Given this list of marker genes TSHZ3, IKZF3, SLC36A2, ORAI2, CTNND1, SEMA4G, IFT140, ABCC4, SLC16A1, SDC3, HYCC1, SKIL, CCT4, GAGE12D, VGLL3, MAP4K1, CDK8, FAM117A (NCBI Gene Id 81558), GCC1, STK4, KRT2, SYP, TIMM21, ATG16L2, MTCH2, CREM, JAZF1, MPPED2, TSPYL4, PAK1, PALS2 (NCBI Gene Id 55569), FRMPD3, PPP2R5C, CELF3, SYT14, CHP1, SYT6, DYDC2, CLIC5, CDK15 (NCBI Gene Id 65061), PRSS27, ATP1B4, RPS6KA2, LURAP1L, STK17B (serine/threonine kinase 17b), SLC1A2, NPY1R, CCL28, AKAP6, DDX6, PPME1, STX11, RBM19, CA6, RAB6C, C1orf105, NIPSNAP3A, MDGA2, RLIM, APOBEC3F, CORO1C, RASSF8, DAB2, SLC39A8, SHOX, MAN2A1, ST6GALNAC5, SF3A3, MKKS, TRIM32, EBAG9, AAK1 (NCBI Gene Id 652453), MARCKSL1, MAML1, IMPG2, PPDPFL, KRT222, IARS1, ARID4A, PSG4, METTL8, TMT1B, SSR2, NT5DC3, HIP1, NAMPT, SNAPC3, EIF4E3, DUSP19, HNRNPL, GABBR1, RAB6D, ZCCHC14, PLBD2, PGPEP1, GAGE1, ARHGAP9, PRR23C, NIPSNAP3B, GPATCH2, PLXNA2, GNGT2, ADAM30, COL4A2, ZNF275, FABP4, PELI1, ENTPD7, SLC6A11, GIGYF1, BCL9, FAM117B, TRDN, UBE3A (ubiquitin protein ligase E3A), GASK1A, SNX20, PATZ1 (NCBI Gene Id 23598), HS6ST2, SUCLA2, PSG1, MYEOV, TSPAN12, GRIN3A, DMP1, SHISA7 (NCBI Gene Id 729956), MXRA5, ELK1 (NCBI Gene Id 2002), NSMCE3, KCNB1, NAV1, PYGO1, FAM199X, MAPK10, BAZ2A, SRRM4, STX5, SH2B3, MEPCE, LOX, TPM1, here is a description of the gene set: Genes predicted to be targets of miRBase v22 microRNA hsa-miR-30c-1-3p in miRDB v6.0 with MirTarget v4 prediction scores > 80 (high confidence targets). Human Gene Set: MIR30C_1_3P studied in species Homo sapiens from publication Chen Y, Wang X (PMID 31504780)